The following is a description of a gene set: species: Homo sapiens Human Gene Set: MIR7154_5P from publication Chen Y, Wang X (PMID 31504780) Genes predicted to be targets of miRBase v22 microRNA hsa-miR-7154-5p in miRDB v6.0 with MirTarget v4 prediction scores > 80 (high confidence targets)., and this is the list of marker genes: LRCH2, PRRG4, UBXN2B, AIG1, ZMYM6, CLTC, KLHL5, CDH19, IL12A, PIK3CB, ZMIZ1, MBNL2, TBX3, PSG11, ZNF572, MYEF2, PI4K2B, ZNF639, YY1, TGIF1, HYAL4 (hyaluronidase 4), CELF5, SNAP25, LCN10, SLC23A2, UBE2QL1, GDA, FN3KRP, STOX2, C1orf141, CFC1, KRAS, EIF2S3, SBSPON, ANKRD49, DFFB, DGKH, TMEM216, SMIM19, CXorf38, ARL5A, COL25A1, TLL2, ANK3, SCN1A, CLEC2D, EVI5, ZNF700, HAPLN1, TOP1, TMEFF2, USP32 (ubiquitin specific peptidase 32), IPMK, PAX3, BTBD7, FAM8A1, POLI, KL (klotho), THSD7B, C5orf24, CHKA, C4orf17, ZBTB20, PAK6-AS1, ZNF540, COL14A1, NFYB, MTBP, MC2R, DUSP21, RNF128, TENM1, TBX22, UHRF2, EBAG9, COL19A1, ITSN1, SLC38A2, CHN2, TRIQK, GRHL1, ECT2L, AQP9, PPFIA1, SCAF1, TOGARAM1, LARGE1 (LARGE xylosyl- and glucuronyltransferase 1), RAB30, BRINP1, SHISA3, PABIR2, NUP107, RAB23, TSPAN13, GLYATL2, MTM1, RPS6KA6, GUCY1A2, SESN3, PAIP2B, GOSR2, GNG4, IL22RA2, ARIH2 (NCBI Gene Id 10425), XPR1, GJA3, NIN, ENY2, ZNF440, PCDH10, B4GALT3, NTN4, ZNF763, LTN1, MAF, PEX11A, ST8SIA4, VBP1, ZIC1, IDH3A, TIMM21, SCN9A, PAPOLG, SPRING1, CLCN3, CEACAM5, PGAP1, SH3GL2, FOXO6 (forkhead box O6), SOCS4, NGLY1, PRR23C (NCBI Gene Id 389152), FBXO38, CA10, FASTKD2, SNTG1, LRRC58, EML1, MACC1, FNDC3A, CCDC126, RSRC2, EFCAB11, GNG5, CUX1, ZNF704, ZNF391, LPAR1, YWHAZ, DDAH1, ABCB10, GNG12, EVA1A, LEKR1, SORBS1, SALL4, ATF7IP, C2CD4C, WWC3, TSNAX, CLIC4, DACH1, XRN1, TBX18, NHLRC3, PWP1, ACAP2, RFX7, NSD1, GALNT15, CERKL, AGR3, MAPK8, RRAGA, EDN1, ZFP1, FAXC, FAM3C, PNISR, CCDC91, PYGO1, MBL2 (NCBI Gene Id 4153), PTPN2, DLL1, TMEM47, NRIP1, ZC3H12B, DPYSL2, USP37, SCN1B, ZNF10, PLXDC2, UST, CDK19, EPHA5, MYLK, ATXN7, BFSP2, FOXD4L5, SOX6, CHL1, SEL1L, EDIL3, RORA, EGF, TRAPPC10, MRPL52, BAAT, WAPL (NCBI Gene Id 23063), DMGDH, FOXP2, MAP2K4, ASAP2, MIER1 (NCBI Gene Id 57708), MTMR12, CEP135, KDM3B, KCTD18, BAZ1A, GDAP1, CTTNBP2, UQCC6, MRTO4, EPAS1 (endothelial PAS domain protein 1), IFNGR1, USP45, WDR33, SH3BGRL, MED13, ZFHX4, TIAL1, LCORL, BLTP3B, FOXD1, MAPK6, ANKRD12, NAMPT, XKR8, TFF2, MYB, CENPBD1P, ASCC3, CBR4, ASIC5, SLC30A6, ARID1B, ZNF615, GRIA3, SDHD, CDK17, LTV1, YBX2, FAM149B1, MEOX2, RSBN1L, KLHL24, PTPN13, OMA1, USP6, EBF3, KCNV1, PABPC5 (poly(A) binding protein cytoplasmic 5), ZNF805, ZNF614, FOXJ1 (NCBI Gene Id 2302), PLEKHA1, CNTN5